The following is a description of a gene set: studied in species Homo sapiens Human Gene Set: REACTOME_INLB_MEDIATED_ENTRY_OF_LISTERIA_MONOCYTOGENES_INTO_HOST_CELL InlB-mediated entry of Listeria monocytogenes into host cell, and this is the list of marker genes: UBB, EPS15, SH3GL1, CBL, SH3GL3, RPS27A, HGS, STAM, SH3KBP1, UBA52, SH3GL2, GRB2, STAM2, UBC, MET